Given this list of marker genes Alox15, Alox12b, Alox12e (arachidonate lipoxygenase, epidermal), Alox5, Alox12, here is a description of the gene set: Mouse Gene Set: GOMF_ARACHIDONATE_12_S_LIPOXYGENASE_ACTIVITY Catalysis of the reaction: arachidonate + O2 = (5Z,8Z,10E,12S,14Z)-12-hydroperoxyicosa-5,8,10,14-tetraenoate. studied in species Mus musculus